The following is a description of a gene set: A membrane-bounded organelle that receives incoming material from primary endocytic vesicles that have been generated by clathrin-dependent and clathrin-independent endocytosis; vesicles fuse with the early endosome to deliver cargo for sorting into recycling or degradation pathways. Mouse Gene Set: GOCC_EARLY_ENDOSOME species: Mus musculus, and this is the list of marker genes: Trak2, Eea1, Myo1b, Arrdc3, Cftr, H2-M2, Wipf3, Rasgef1b, Vps8, Erbb2, D130043K22Rik, Tbck, H2-Q10, Ldlr, Epha3, Tmem30a, Htt (huntingtin), Rab5b, Wdfy2, Cytip, Flot1, Washc1, Rap1gap, Mr1, Abcb6, St8sia2, Ankrd13b (NCBI Gene Id 268445), Vcam1, Mlc1, H2-Q7, Appl2, P2ry2, Ntrk1, Tpd52l1, Tpcn1, Tlr3, Uts2r (urotensin 2 receptor), Ap1b1, Ankfy1, Nucb1, Mme, Angptl3, H2-K1, Hap1, Wdfy4, Marchf3, Slc5a7, Rab29, Dop1b, Plekhj1, Ptp4a2, Ptp4a1, Meltf, Litaf, Psen1, Snx5, Tmem108, Akt2, Samd9l, Pheta1, Ppp1r21, Usp8, Nf2, Vps33a, Map2k2, Ptpn23 (NCBI Gene Id 104831), Kcnh1 (potassium voltage-gated channel, subfamily H (eag-related), member 1), Rab31, Gpnmb, Rcc2, Wdfy1, Myo5a, Atp6v0d2, Mmgt2, Rab32, Ldlrap1, Ifitm7, Tmem127, Mvb12b, Picalm, Mtmr2, Nrp1, Vamp3, Steap2, Kir3dl2, Marchf8, Stam2 (signal transducing adaptor molecule (SH3 domain and ITAM motif) 2), Map2k1, Napepld, Zfyve28, Ifitm2, Ehd4, Wasf2, Uvrag, 2610528J11Rik, Eps15, Psen2, Snx12, Rcsd1, H2-Ab1, Fzd5, Rab5a, Neurl1b, Abca7, Pheta2, Tom1, Sgk3, Rab4a, Stx7, Sort1, Rab4b, Anxa1, Atp11b, Ackr2, Atp9a, Ubxn6, Cln3, Lipc, Numb, Rab34, Astn2, Kir3dl1, Rhob, Slc11a2, Zfyve16, Lipg, Inpp4a, Siglec1, Atp11c, Rin3, Dbnl, Gripap1, Slc9a9, Ehd3, Arl8b, H2-M10.1, Ret, Anxa2, H2-Q2, Tbc1d2b, Snx31, Cd274, Stam (NCBI Gene Id 20844), Rab14, Siah1a, Siah1b, Nox1, Tgfbrap1, Vps4a, Ap3d1, Dysf, Lamp5, Adrb1, Tbc1d16, Cryzl1, Atp11a, Plekhf2, Furin, Hps6, Rap1a, Ltf, Ifitm1, Chmp3, Vps26a, Tmem184a, Ehd1, Inpp5f, Atp13a3, Entrep1, Vps11, Appl1, Clip3, Stx8 (NCBI Gene Id 80802), Ccdc93, Snx17, Hyal3, Fkbp15, Mgrn1, H2-M11 (NCBI Gene Id 224754), Ap3b2, Itch, Ap1m1, Bltp3b, Vipas39, Ncstn, Pld4, Tlr4, Ticam2, Pmepa1, Mcoln3, Vamp8, Tmem230, Nsg1, Aoc3, Ap3m2, Vps13b, Vps16, Ap3s2, Ap3m1, Snx7, Rhod, Clvs1, Mtmr4, Ap4m1, Hgs, Sh3gl3, Pcsk9, Rabgef1, Bace1, Lmtk2, Ank2, Rab5c, App, Ap1g1, Nsg2, Rufy1, Rab21, Dnajc13, Snx16, Rab17, Gatd1, Lrp1, Ap3s1, Vps35, Snx27, Inhca, Gria1, Trio, Kcnq1, Cacng7, Tollip, Ankrd27, Snx3, Mapkap1, Hmgb1, Ackr3, Ackr1, Ptp4a3, Rabep2, Mapk3, Slc1a1, Plekhf1, Trim27, Ephb1, Slc9a6, Slc9a3, Arap1, Clcn4, H2-M3, Rps6kc1, Atp13a4, Sorl1, Kif16b, Fgd5, Ctss, Rac1, Cd1d1, Ldlrad4, F2r, Fgd2, Rubcn, Rabgap1l, Gga2, Clcn5, Ap1s1, Cln6, Pdlim4, Washc4, Rab1a, Lamp3 (NCBI Gene Id 239739), Myo1d, Bloc1s1, Pick1, Hspd1, Mib2, Havcr2, Derl2, Cntnap2, Snx6, Or51e2, Rbsn, Plpp2, Ap1s3, F2rl1, Arf6, Phb1, Parm1, Usp10, Ifitm3, Rnft1, Vps28, Aph1a, Wdr91, Trappc9, Rftn1, Coro1a (coronin, actin binding protein 1A), Snx1 (sorting nexin 1), Mmgt1, Vps26b, Atp6v0d1, Neu3, Serpinb1a, Fcmr, Ocrl, Magel2, Slc31a1, Commd1, Inpp5b, Slc39a14, Ntrk2, Slc2a13, Ptpn1, Apbb2, Pla2g4e, H2-T22, Cmtm6 (NCBI Gene Id 67213), Pld3, Arc, Washc5, Stx12, Nipa1, Tsg101, H2-M10.4, Pi4k2b, Sh3glb1, Apoa5, Atf6b, H2-Q1 (histocompatibility 2, Q region locus 1), Epha8, Rab22a, Mon2, Dagla, Clcn3, Plekha3, Rep15, Pla2g4b, Clvs2, Atp7a, Washc3, H2-Q6, Bok (BCL2-related ovarian killer), Stx6, Trf, Ticam1, Ece1, Marchf1, H2-D1, Rab11fip5, Ccdc154, Ehd2, Snx4 (sorting nexin 4), Tmem63a, Slc15a4, Gper1, Snx13, Nae1, Als2, Eqtn, Vps41, Egfr, Zmpste24, Slc30a10, Nme1, Igf2r, Entr1, Sh3gl2, Apoe, Dtx3l, Zfyve26, Laptm4b, Mapk1, Rabep1, Ap1s2, Snx21, Llgl1, Aqp2, Cxcr4, Vps33b, Gja1, Siah2, Epha4, Gga1 (golgi associated, gamma adaptin ear containing, ARF binding protein 1), Ap3b1, F8a, Ecpas, Vps18, Gzmb, Derl1, Sorcs2, Hps3, Pacsin2 (protein kinase C and casein kinase substrate in neurons 2), Tmem63b, Sh3gl1, Slc5a1, H2-M10.6, Rapgef1, Snx2, Tmem9b, Snx20, Snx8, Gga3, Gpr107, Kdr, Trim3, Wdr81, Neurl3, Nipa2, Zfyve9, Rab20, Slc35d3, Osbpl6, D6Wsu163e, Rnd2, Pi4k2a (NCBI Gene Id 84095), Stambp, Tmem163, Hsd17b6, Hps5, Chmp1a, Pml, Cd22, Washc2, Sphk1, Ackr4, Prdx3, Trak1, Rnf11 (ring finger protein 11), Rab38, Dner, Tlr9, Tm9sf4 (NCBI Gene Id 99237), Kifc1, H2-M10.2, Syndig1, Steap4, Wls, H2-M5, Snx30, Adrb2, Arrdc4, Nisch, Slc17a6, Vti1b, Lrp6, Tfrc, Rusc1, Pikfyve, Hfe, Cd300ld3